Given this list of marker genes FER, UBB, REC8, TBC1D20, INHBB, ATRX, SCAPER, LHCGR, KIF18A, MCIDAS, WDR48, SMAD4, ODAD3, GMNC, DNAAF3, ADGRG1, BRIP1 (BRCA1 interacting helicase 1), AR, ING2, SPATA2, CCNO, here is a description of the gene set: studied in species Homo sapiens Human Gene Set: GOBP_SEMINIFEROUS_TUBULE_DEVELOPMENT The reproductive developmental process whose specific outcome is the progression of the seminiferous tubule over time, from its formation to the mature structure. Seminiferous tubules are ducts located in the testicles, and are the specific location of meiosis, and the subsequent creation of gametes, namely spermatozoa.